Given this list of marker genes SON, CDC6, CARS1, KIF7, CDH11, PPP2R5D, KAT6B, AMMECR1, MAP2K1, GRHL3, ZSWIM6, BICRA, DGCR2, PRR12, GMNN, CDC45 (cell division cycle 45), FOXP2, TP63, LARGE1, KAT5, NSUN2, KCNK9, BRAF, DAG1, PTDSS1, GDF11, LMNA, STAG2, ESS2, DGCR8, POMT2, SIX3, NEK1, MAP2K2, HYAL1, ZMPSTE24, CRPPA, ORC4, B3GALNT2, HYLS1, RAD21, AHDC1, FOXI3, SET, CUL3, SMAD4, CDT1, POLR3A, TCTN3, POMGNT2, BCOR, POMK, SMCHD1, NONO, TBX1, SOX6 (NCBI Gene Id 84363), PIEZO2, POMT1, HAAO, ORC1, SIAH1, LIG4 (DNA ligase 4), COL4A1, B4GAT1, GNPAT, UBB, KRAS, POMGNT1, DGCR6, FKRP, PRKAR1B, ORC6, WBP11, RXYLT1, HS2ST1, AMER1, COL2A1, DHCR24, RPS23, STAC3 (NCBI Gene Id 246329), RNU4ATAC, FKTN, ZEB2, SOX9, IPO8, here is a description of the gene set: Human Gene Set: HP_SUBMUCOUS_CLEFT_PALATE Submucous cleft palate A cleft of the muscular portion of the palate that is covered by mucous membrane. studied in species Homo sapiens